The following is a description of a gene set: species: Homo sapiens Human Gene Set: HP_EXERTIONAL_DYSPNEA Perceived difficulty to breathe that occurs with exercise or exertion and improves with rest. Exertional dyspnea, and this is the list of marker genes: SFTPA2, TBL1XR1, CAP2, SGCD, RPL3L, BAG5, ACTC1, VCL, DPP9, MYH6, PML, MYH11, DMD, NEXN, BAG3, PLEC, NEB, AGR2, PRKAR1A, DNA2, SLC25A4, ABCA3 (NCBI Gene Id 21), COLQ, MFAP5, TERC, COL13A1, JAK2, ENG, PPCS, AGRN, EIF2AK4, ACADM, TAF1A, TGFB3 (NCBI Gene Id 7043), MAT2A, IRF2BP2, ATP11A, RAF1, FHL2, CHRND, CHRNE, CRYAB, MUC5B, NKX2-5, FOXE3, RBM20, TBX20, NUMA1, GET3, HEY2, SMAD4, TLL1, DOK7, CYB5A, TMPO, TCAP, ABCC9, DOLK, FKTN, COA8, LAMA4 (laminin subunit alpha 4), STAT5B, NABP1, JPH2, TNNT2, POLG, SURF1, PRDM16, ZBTB16, DES, RRM2B, FIP1L1, MYPN, RAPSN, PYGM, SCN5A, STAT3, SCN4A, ATP13A3, LMNA, GYG1, VEZF1, PSEN1, CSF2RB, TNNI3, DSG2, PLN, CITED2, LDB3, ZMPSTE24, PIEZO2, SFTPC, SMAD3 (SMAD family member 3), TWNK, TTN, GATA4, TPM1, ACTA2, TGFBR1, SMAD2, ELN, THSD4, TRMT5, TAFAZZIN, STN1, LRP4, BCOR (BCL6 corepressor), ACTN2, SDHA, CHRNB1, HAND2, SH2B3, TXNRD2, CYB5R3, LAMB2, DSP, FAM13A, TERT, MYBPC3, NPM1, RTEL1, MYLK, GATAD1, MYL3, TGFB2, LOX, PARN, AK9, ANKRD1, SLC34A2, TNNC1, MT-TN, EPOR, FBN1 (fibrillin 1), GATA6, CSRP3, RARA, MUSK, POLG2, TGFBR2, MYH7, PSEN2, PRKG1, LMOD2 (NCBI Gene Id 442721), CHRNA1, SFTPA1